Given this list of marker genes ADORA2B, MIR1269B, HS3ST3B1, DNAH9, RPL21P122, LINC02096, RNU6-314P, SNORA74, ZNF18, TEKT3, COX10-DT, RNU6-799P, ENSG00000232058, TMEM238L, RPS18P12, TBC1D26, MIR4731, TRIM16 (NCBI Gene Id 10626), ENSG00000265445, ZNF286A-TBC1D26, MYOCD, ELAC2, SHISA6, CDRT15, RNA5SP436, ZSWIM7, CDRT15P2, PMP22, LINC02087, CDRT15P1, TTC19, RPLP1P11, CDRT4, CDRT7, ZNF286A, TBC1D26-AS1, TVP23C-CDRT4, RPL9P2, PPIAP53, RN7SL792P, UBE2SP1, MEIS3P1, LINC02093, RNU6-1065P, RN7SL601P, TVP23C, PIRT, MIR744, MAP2K4, RPL23AP76, ARHGAP44-AS1, HS3ST3A1, MYOCD-AS1, LINC00670, FBXW10B, ZNF29P, RNU11-2P, COX10, ARHGAP44, RPL22P21, SPECC1P1, RPL15P21, CDRT8, MIR548H3, IL6STP1, ZSWIM5P1, here is a description of the gene set: Human Gene Set: chr17p12 studied in species Homo sapiens